The following is a description of a gene set: species: Homo sapiens Genes having at least one occurence of the motif ACCATTT in their 3' untranslated region. The motif represents putative target (that is, seed match) of human mature miRNA hsa-miR-522 (v7.1 miRBase). Human Gene Set: ACCATTT_MIR522, and this is the list of marker genes: UBE3A, CRIM1, TSSK1B, CPD (carboxypeptidase D), ANO1, MYCBP2, YWHAQ, GPM6B, RBM22, NR4A3, C2CD6, FLRT3, HNRNPK, PTPN11, CEMIP2, PTGFRN, ZC3H7A, UBE2L3, ARID5B, ARHGAP29, CASKIN1, PRKG1, TMEM266, ATP1B1, CSPG5, CBLL1, ELAVL1, KDM2B, PANK2, CDV3, VAPA, HBP1, TNRC6B, FEM1C, CTBP1, CSDE1, GOLGA1, ETV1 (NCBI Gene Id 221810), ZFP36L2, TCFL5, MAFB, LRCH2, MEF2D, GNAO1, MTDH, NAA50, HMGXB4, RTF1, WNK3, SPTBN1, CSNK1A1, PLAG1, BRD8, BHLHE22, SLC39A9, EHMT1, RNF2 (NCBI Gene Id 6045), IVNS1ABP, HNRNPM, PPM1E, KATNBL1, CELF2, EWSR1, HOXB5, TGDS, NFE2L2, NHS, ZNF532, EIF2A, TOPORS, ARHGAP5, ZC3H12B, UBTD2, DAG1, CDS2, RSBN1, TLX1, BPNT2, NFKBIZ, JOSD1 (Josephin domain containing 1), FOXP1, ENC1, PPP4R3B, TTN, FZD2, ZRANB2, APH1A, PLK2, FMR1, CNTFR, ING3, ARID2, UBE2Q2, SALL1, PERP, NAB1, SOX9, YWHAZ, SH3BP5, ZNF384, MECP2, PHYHIPL, MYEF2, LMO3, CUL1 (NCBI Gene Id 8454), RTKN2, AQP9, UBE2N, CAPN3, CAPRIN1, ARMCX2, KIF23, JUN, NPAT, TOP1, UBE2J1, KRTAP3-1, GAB2, SP4, UBE2NL, KRAS, TBC1D8, CSNK1A1L, EVI5L, AMMECR1L, DYRK1A, AKAP1, SLC7A6, CCND2, RPGRIP1L, MAN1A2, AKAP9, STAG1, DNAJC25, KPNB1, PRPF39, FAM114A1, NMNAT2, WDTC1, ACAP2, TMEM168, UBA2, CEBPA, PTPN1, MSL2, TRPM7, MYH10, TAFA1, MBNL1, SYNCRIP, ATRX, EIF4H, TNPO2, RBMXL1, DOCK7, SUCO, LRP1B, CMPK1, GARRE1, RBMX, ZC3H11A, WDR26